The following is a description of a gene set: species: Homo sapiens The mitotic cell cycle phase transition whose occurrence commits the cell from the G0 quiescent state to the G1 phase. Under certain conditions, cells exit the cell cycle during G1 and remain in the G0 state as nongrowing, non-dividing (quiescent) cells. Appropriate stimulation of such cells induces them to return to G1 and resume growth and division. The G0 to G1 transition is accompanied by many changes in the program of gene expression. Human Gene Set: GOBP_G0_TO_G1_TRANSITION, and this is the list of marker genes: RRM1, SMARCE1, SMARCC2, CDKN2B, SOX15, PPP2R5B, ZNHIT1, RRM2B, ARID1A, MIR503, DAB2IP, ACTB, MED1, BCL7B, ACTL6B, PHF10, ARID1B, HLA-G, LIN37, SMARCD2, RHNO1, CDK3, CCNC, BCL7C, BRD7, DPF2, ACTL6A, BCL7A, DPF3, SMARCA2, ARID2, SMARCC1, SMARCD3, FOXO4, PBRM1, SMARCA4, SMARCB1, CHEK1, DUX4, SMARCD1, DPF1, MIR424